The following is a description of a gene set: Human Gene Set: GSE8921_UNSTIM_0H_VS_TLR1_2_STIM_MONOCYTE_6H_UP from publication Liu PT, Stenger S, Li H, Wenzel L, Tan BH, Krutzik SR, Ochoa MT, Schauber J, Wu K, Meinken C, Kamen DL, Wagner M, Bals R, Steinmeyer A, Zügel U, Gallo RL, Eisenberg D, Hewison M, Hollis BW, Adams JS, Bloom BR, Modlin RL (PMID 16497887) Genes up-regulated in monocytes: untreated versus M. tuberculosis 19 kDa lipopeptide (6h). In innate immune responses, activation of Toll-like receptors (TLRs) triggers direct antimicrobial activity against intracellular bacteria, which in murine, but not human, monocytes and macrophages is mediated principally by nitric oxide. We report here that TLR activation of human macrophages up-regulated expression of the vitamin D receptor and the vitamin D-1-hydroxylase genes, leading to induction of the antimicrobial peptide cathelicidin and killing of intracellular Mycobacterium tuberculosis. We also observed that sera from African-American individuals, known to have increased susceptibility to tuberculosis, had low 25-hydroxyvitamin D and were inefficient in supporting cathelicidin messenger RNA induction. These data support a link between TLRs and vitamin D-mediated innate immunity and suggest that differences in ability of human populations to produce vitamin D may contribute to susceptibility to microbial infection. species: Homo sapiens, and this is the list of marker genes: MTR, OTX1, STOML2, PSMC5, CTTNBP2, TIMM8B, OLIG3, ACSF3, NDC80 (NDC80 kinetochore complex component), RRP7A, ATP6V0E2, TULP2, CTNNBL1, UTP4, AURKAIP1, CSF3R, TTLL12, MTG1, FGF6, CEACAM20, ALG3, CRISP2, FAM170B, DAB2IP, CC2D2A, TMEM216, VIT, PAOX, POGLUT3, SMR3A, GZMH, ACADS, XRCC6, TSR3, NRF1, PABPN1, NTSR2, KCND3, GNL2, SEMA6A, MPND, PMPCA, CBR4 (NCBI Gene Id 84869), PSAT1, DAB1, CCNYL1, FASTKD1, TAGLN2, TIGAR, POLE4, HMGN3, TESC, HSPB7, MTHFD2, MICOS10, DPP3, DPH5, NDN, ENAM, BANF1, ATF5, ST3GAL1, EMC4 (ER membrane protein complex subunit 4), PRXL2B, COX6C, FILIP1L, RERE, SLC26A10P, KRTAP26-1, CRABP1, EIF2B3, MTFP1, COX6A1, NUP155, NRG1, CRYGB, TNC, HDC, MRE11, SMPD3, PSMB1, BLNK, MDC1, PYROXD1, VEZT, GAA, POGLUT2, EHD4, LRFN2, MALSU1, YARS2, TMEM100, MID1IP1, MRPL36, FUOM, ESRRG, RPP40, CIAPIN1, PSEN2, TNFAIP8, ISY1, NXF2, AMPD2, ZIC1, MRPS26, PDLIM1, RBFOX2, SPINT1, S100A6, USP12, CDC26, SLC7A11, FAM118B, CYB5R1, THAP11, HNRNPAB, HAS2, CDC23, GORASP1, ADCY5, PES1, DAPL1, MRPS10, ALKBH1, ST3GAL5, AAGAB, IGKC, NDUFS7, ANKRD27, SMG7, GYG1, KDF1, MXRA8, TMEM88B, CYP4F12, TJP2, JMJD8, MMADHC, PAK6, PLXNC1, OTOR, CEACAM21, ANKRD13D, SF3A1, CDCA8, NUF2, ADARB1, TRPM5, NDUFB9, C22orf39 (chromosome 22 open reading frame 39), OSR1, GATB, SCAF11, CENPW, ESPL1, RUVBL2, PJA1 (praja ring finger ubiquitin ligase 1), BLVRA, DDX11, HSBP1, RAPH1, CAB39L, FIRRM, MRNIP, LAP3, PSMD1, ARHGEF28, CNTNAP4, ACKR2, CYFIP2, LIG1, MTARC2, ZIC4, KRTAP2-4, ZNF821, HSPD1, RRAGA, HIKESHI, EME1, FADS6, THNSL2, AKR1D1, POLD2, TMED3, NDUFB6, ARF1, HYPK, DNAJC24, POLR2F, ZNF35, OSCP1, MERTK, EBI3 (NCBI Gene Id 10148), NSUN2, ETV5, TINF2, KIN (NCBI Gene Id 22944), COX18, SPIRE1, IRAG2